Given this list of marker genes AP1G1, PACS1, AP1M1, B2M, AP1S2, AP1M2, AP1S3, HLA-A, AP1B1, AP1S1, here is a description of the gene set: Human Gene Set: REACTOME_NEF_MEDIATED_DOWNREGULATION_OF_MHC_CLASS_I_COMPLEX_CELL_SURFACE_EXPRESSION Nef mediated downregulation of MHC class I complex cell surface expression species: Homo sapiens